The following is a description of a gene set: studied in species Mus musculus electronically inferred by orthology from the curated human pathway This event has been computationally inferred from an event that has been demonstrated in another species.<p>The inference is based on the homology mapping from PANTHER. Briefly, reactions for which all involved PhysicalEntities (in input, output and catalyst) have a mapped orthologue/paralogue (for complexes at least 75% of components must have a mapping) are inferred to the other species. part of: Organelle biogenesis and maintenance Reactome Pathway: Cilium Assembly, and this is the list of marker genes: Ift88, Ift22, Ttc8 (tetratricopeptide repeat domain 8), Dync2i1, Bbs2, Cep89, Nde1, Dynlrb2, Dynlt2a2, Tubb4b, Ywhae, Nphp1, Cep57, Sdccag8, Dynll1, Rab3ip, Ift57, Atat1, Tuba8, Mchr1, Cct2, Ttc21b, Prkaca, Bbs10, Cep41, Cep131, Rab11a, Tuba3b, Csnk1e, Cep43, Tuba1c, Cct3, Ift25, Cct5, Cep152, Rab8a, Ift74, Dynlt2a3, Cdk1, Haus5 (NCBI Gene Id 71909), Tctn3, Bbs7, Tctn2, Exoc2, Cluap1, Exoc7, Dctn1, Actr1a, Ift80, Nphp3, Plk1, Tuba1b, Cep63, Haus1, Kif3c, Cnga4, Cenpj, Inpp5e, Cep135, Cep83, Asap1, Ift81, Smo, Tubb4a, Haus8, B9d1, Dynlt5, Kifap3, Tubal3, Tubb6, Tuba4a, Nedd1, Exoc1, Arl3, Cep192, Prkar2b, Cct8, Rp2, Haus7, Sstr3, Mks1, Sfi1, Ift172, Tuba1a, Clasp1, B9d2, Cngb1, Ift70b, Wdr35, Ift70a1, Ninl, Cep72, Ift27, Dync2i2, Tubb2b, Rho, Lztfl1, C2cd3, Bbs1, Cep290